Given this list of marker genes Trmt2a, Sdcbp2, Pbx2, Hnf1b, Thrap3, Rab1a, Zfp950, Cct4, St6galnac5, Gm14151, Slc49a4, Hapln1 (NCBI Gene Id 12950), Pcdh17, Faxc, Fasl, Akap12, App, Cnksr3, Entpd1, Fgf10, Sh3pxd2a, Slc9a9, Alyref2, Crxos, Oxtr, Ints3, G2e3, Ralyl, Jade1, Esr1, Rpl27a, Degs2, Slc41a1, Prlr, Ss18, Cpsf7 (NCBI Gene Id 77197), Lrrc18, Cfap43, Ctnnb1, Large1, Epg5, Gabrp, Cdc42ep2, Tspan10, Mplkip, Ywhaz, 4930453H23Rik, Slc25a5, Rtl8a, Pcdh12, Eea1, Ptk2b, Arl5b, Tas1r3, Myh10, Gmeb1, Vsnl1, Pcm1, Pcdh15, Kank2, Ccnyl1, Rfx3, Zfp740, Sh2b1, Zswim8, Rrad, Ccdc71l, Izumo3, Tfip11, Fbxo32, Arel1, Sdhaf3 (succinate dehydrogenase complex assembly factor 3), Ankle2, Ncor2, Nploc4, Grik3, Sgpp2, Gspt1, Igf2, 4921509C19Rik, Kat6a, Twist1, Ankrd39, Kcnip1, Dram1, Calhm4, Zdhhc14, Ppp3cb, Akna, Col9a3, Rnf4 (ring finger protein 4), Mbnl2, Atp2a2, Uhrf2, Bmpr1a, Sertad2, Adnp, Drp2, Zdhhc8, Car10, Phf6, Wdr26, Sult1b1, Rtl8b, Ambra1 (autophagy/beclin 1 regulator 1), Ddx19b, R3hdm2, Hnrnpr, Clptm1, Dock3, Rnf187, Jph1, Emx2, Rnf2, Krt4, Ap1g1, Slc25a36, Ralgapa1, here is a description of the gene set: species: Mus musculus Mouse Gene Set: MIR_6914_3P Genes predicted to be targets of miRBase v22 microRNA mmu_miR_6914_3p in miRDB v6.0 with MirTarget v4 prediction scores > 80 (high confidence targets). from publication Chen Y, Wang X (PMID 31504780)